The following is a description of a gene set: Vitamin C (ascorbate) metabolism species: Homo sapiens Human Gene Set: REACTOME_VITAMIN_C_ASCORBATE_METABOLISM, and this is the list of marker genes: CYB5A, SLC23A1, SLC2A3, SLC2A1, GSTO1, CYB5R3, SLC23A2, GSTO2